Given this list of marker genes Itm2b (integral membrane protein 2B), Jak3, Itm2a, Acot8, Slc2a10, Abca7, Mgat4d, Bace2, Aatf, Hbegf, Oga, Ago2, Itm2c, here is a description of the gene set: species: Mus musculus Mouse Gene Set: GOBP_NEGATIVE_REGULATION_OF_GLYCOPROTEIN_BIOSYNTHETIC_PROCESS Any process that decreases the rate, frequency, or extent of the chemical reactions and pathways resulting in the formation of a glycoprotein, a protein that contains covalently bound glycose (i.e. monosaccharide) residues; the glycose occurs most commonly as oligosaccharide or fairly small polysaccharide but occasionally as monosaccharide.